Given this list of marker genes CTNNB1, SEPTIN2, EXOC7, MAPK14, WASL, CDH1, PIK3R1, JUN, ACTR2, MAP3K11, ARPC3, PAK4, ARHGEF7, ARPC5, MTOR, HES5, HRAS, LIMK1, GSK3B, RAC1, MAP2K3, PRKCE, TIAM1, BAIAP2, RPS6KB1, TNK2, MAPK1, BRAF, MAPK8, PAX6, SRC (SRC proto-oncogene, non-receptor tyrosine kinase), YES1, PARD6A, PIK3CA, ENAH, ARPC4, MAP2K7, MAP3K1, PRKCZ, ARPC2, ACTR3, CFL1 (NCBI Gene Id 1072), MYL2, CBL (NCBI Gene Id 867), MAP2K6, PLD1, CDC42, ARPC1B, DIAPH3, RAF1, CDC42BPA, ATF2, IQGAP3, MAPK3, PAK1, PAK2, ARHGDIA, IQGAP1, DLG1, F2RL2, ARHGEF6 (Rac/Cdc42 guanine nucleotide exchange factor 6), BCAR1, MAPK9, VAV2, MAP2K4, RASGRF1, LIMK2, APC, EPS8, CTNNA1, here is a description of the gene set: Human Gene Set: PID_CDC42_PATHWAY CDC42 signaling events studied in species Homo sapiens from publication Schaefer CF, Anthony K, Krupa S, Buchoff J, Day M, Hannay T, Buetow KH (PMID 18832364)